Given this list of marker genes L3HYPDH, DSEL, GALM, GFUS, RENBP, RPEL1, YJEFN3, RPE, DHRS9, GLCE, GALE, AMACR, GNE, SDSL, MCEE, SRR, FUOM, DSE, NAXE, here is a description of the gene set: Human Gene Set: GOMF_RACEMASE_AND_EPIMERASE_ACTIVITY studied in species Homo sapiens Catalysis of a reaction that alters the configuration of one or more chiral centers in a molecule.